The following is a description of a gene set: Human Gene Set: GOBP_OLEFINIC_COMPOUND_METABOLIC_PROCESS The chemical reactions and pathways involving an olefinic compound, any compound which contains a carbon-carbon double bond (aka C=C). studied in species Homo sapiens, and this is the list of marker genes: CYP2A7, ADM, FAAH, CREB1, AWAT1, CYP4Z1, ACAA1, LIPE, ADH7, CYP2C18, GGCX, RDH8, DAGLA, CYP11B2, RETSAT, CYP2U1, SDR9C7, PNPLA4, PNPLA2, ADH4, PLA2G2F, CYP2J2, FSHB, CYP2D6, CYP1A2, HSD17B4, DGAT2, PLA2G4B, AKR1C3, BCO1, SDR16C5, CYP19A1, ALDH1A3, PNLIP, CYP2S1, BMP6, CYP17A1, FADS1, AWAT2, BGLAP, PTGS2, GSTP1, LRAT, AKR1B10, DHRS4L1, RDH14, ACOT8, ELOVL5 (NCBI Gene Id 60481), REST, CYP4F2, ELOVL3, CYP2E1, ABCD1, AKR1C2, RBP4, GRIN1, SCNN1B (sodium channel epithelial 1 subunit beta), ELOVL1, SCP2, ADH1C, ADH1A, PNPLA8 (NCBI Gene Id 50640), ABCA4, SRD5A2, BMP2, CYP4F11, CYP3A5, SRD5A1, HSD17B3 (NCBI Gene Id 3293), ELOVL2, STAT5B, ALDH1A2, ALOX5, CACNA1H, PLB1, DHRS4, ABHD12, ABHD6, CYP4F12, EHHADH, RDH13, CYP4A11, CEL, RDH10, TMEM135, CYP4F8, CYP2C19, CLCN2, CYP2A13, GPX4, AKR1C1, BCO2, CYP2A6, DAGLB, STARD3 (NCBI Gene Id 10948), PLA2G4A, DAB2, AKR1B15, DKK3, ALOX12B, CYP4F3, DKKL1, ALOX15, EGR1, CYP1B1, INHBA, CYP27C1, DHRS3, RDH5, DHRS4L2, RDH11, CYP2B6, MGST3, H6PD, LHB, DHRS7, GPX1, PTGS1, CYP11A1, ADH6, ACSL1, HSD11B2, RDH12, CYP3A7, PLA2G4C, CYP11B1 (cytochrome P450 family 11 subfamily B member 1), CYP2C9, PRKG1, WNT4, HSD17B6, CYP46A1, EDNRB, DGAT1 (NCBI Gene Id 8694), BMP5, ALOXE3, ACSL4, DGKQ, CTHRC1, AKR1C4, ADH1B, HSD17B1, AKR1B1, FAAH2 (NCBI Gene Id 158584), ALOX15B, CYP1A1, EPHX2, RDH16, CYP3A4, CYP2C8, PLA2G10, CYP2F1, FADS2, ABCD2, ALOX12, DHRS9, GSTM2, ALDH1A1, AFP, GSTA1, MGLL, ALDH8A1, EPHX1, RPE65, GPRC6A, ACOX1, CYP4A22